Given this list of marker genes PURA, ETNK1, LRRC58, GNB5, KCNAB1, SPRED1, ITGA9, INPP5E, PTPRC, CPM, SEPTIN7, PLXDC2, XPO4, COL6A6, DNAJC24, TRMT10A (tRNA methyltransferase 10A), PDE5A, SLC12A2, UBE2D1, DSE, ATP6V1G1, UST (NCBI Gene Id 10090), CRADD, GNPDA2, MPLKIP, CLIC2 (chloride intracellular channel 2), EPC2, ZBTB25, POLR2K, TRIM50, PSEN2, FAM81A, CSF2, COL4A4, PURG, EBF1, SAMD12, APOBEC3H, AK3, FAM13B, ZNF519, ENTPD1, TPH2, GALR1 (NCBI Gene Id 2587), DIAPH3, MBTD1, ZBTB20, CNOT9, SREK1IP1, FCF1, PLAG1 (NCBI Gene Id 7996), BACH2, CCDC82, HOMER1, PAQR3, FMR1, PRR27, SWSAP1, UGT2A2, INA, POC5, GFRA2, FRA10AC1, SBSPON (somatomedin B and thrombospondin type 1 domain containing), PCSK5, DSP, CLOCK, ZNF346, VTA1, VCPIP1 (valosin containing protein interacting protein 1), TMTC3, LINC02898, LPP, HYDIN, ZNF664, IGF1, SEPTIN14, TCEA1, CHL1, PPP1CC, MYH10, BVES, LIX1, FAM110B, IDI2, FAM120B, HS3ST1, AP2B1, SLC2A13, EXOSC8, USP38, SMARCAD1, SENP2 (NCBI Gene Id 59343), TRAPPC3L, MEX3C, PDK3, ALCAM, BOLA3, COX20, UTP25, PSMD12, ANXA4, ATXN1, UGT2A1, SYN2, G3BP2, SKIL, UBL3, GRIA2, TRIM58, AK9, SCAI, CCSER1 (NCBI Gene Id 80730), NUDCD2, TENT4B, ADCY9, PPP2R3A, MMUT, ZFHX3, CHD1, API5, INO80D, FLRT3, SMARCA4, ILF2, GNAQ, RC3H1, RBM45, here is a description of the gene set: species: Homo sapiens Genes predicted to be targets of miRBase v22 microRNA hsa-miR-8076 in miRDB v6.0 with MirTarget v4 prediction scores > 80 (high confidence targets). from publication Chen Y, Wang X (PMID 31504780) Human Gene Set: MIR8076